The following is a description of a gene set: The reorganization or renovation of existing tissues. This process can either change the characteristics of a tissue such as in blood vessel remodeling, or result in the dynamic equilibrium of a tissue such as in bone remodeling. species: Mus musculus Mouse Gene Set: GOBP_TISSUE_REMODELING, and this is the list of marker genes: Pparg, Hoxa3, Pbrm1, Mmp2, Umod, Itgav, Slc4a2, Jag1, Plg, Cyp1a1, Ltbp3, Abr, Mir29a, Foxc1, Mdm2, Cav1, Rab3d, Dcstamp, Ncdn, Sfrp1, Il6, Elf3, Crb1, Dll4, Tmbim1, Traf6, Cd24a, Mmp9, Atp7a, Nox4, Hamp, Efna2, Hif1a, Il7, Epha2, Tnfrsf11a, Nol3, Cela1, Tgm2, Tgfbr3, Chaer1, Src, Inpp4b (inositol polyphosphate-4-phosphatase, type II), Rac2, Lrp1, Ihh (NCBI Gene Id 16147), Rbpj (NCBI Gene Id 791349), Tcirg1 (T cell, immune regulator 1, ATPase, H+ transporting, lysosomal V0 protein A3), Rock1, Gpr55, Pth1r, Hnf1a, Tpp1, Ahr, Thbs4, Grem1, Stat5a, Atg5, Col6a1, Csf1r, Spp1, Tns3, Lepr, Ptn, Ceacam1, Plekhm1, Rock2, Ankrd11, Cthrc1, BC004004, Fshr, Fcgr4, Ppargc1b, Calcr, Vegfa, Tfrc, Gpr137b, Capn1, Lipa, Ugt1a1, Siglec15, F2r, P2rx7, Ctsk, Gsk3b, Mdk, Timp1, Inpp5d, Ctnnb1, Htr1b, Acvr2b, Bcr, Sema3c, Gnat2, Npr3, Tbx1, Wnt16, Pml, Cartpt, Ddr2, Cd38, Dock5, Ndp, Npr2, Chd7 (NCBI Gene Id 57137), Itgb3, Notch2, Axl, Klf6, Arap1, Fam114a1, Il18, Ptk2b, Angpt2, Spp2, Fshb, Adrb2, Nppc, Egfr, Syk, Fgf10, Il1a, Rufy4, Gpnmb, Bak1 (NCBI Gene Id 12018), Lrrk1, Snx10, Itga4, Cldn18, Ccdc154, Tnfrsf11b, Herc1, Gja5, Acvrl1, Lrp5, Ppp3ca, Abcb1b, Trf, Adra1b, Mitf, Dbh, Tie1, Fgfr3, Vdr, Prkca, Epas1, Fkrp, Def8, Fgf8, Slc34a1 (solute carrier family 34 (sodium phosphate), member 1), Nos3, Mir29b-1, Cspg4, Iapp, Suco, Oscar (osteoclast associated receptor), Cbl, Tgfb2, Gdf5, Nf1, Syt7, Mmp14, Csk, Lif, Rac1, Lep (leptin), Agt, Il23a, Ednra, Clec10a, Ccr2, Acp5, Rassf2, Hrg, Adam8, Cdkn2a, Flt4, Tph1, Enpp1, Hand2, Tmem64, Rab7 (RAB7, member RAS oncogene family), Fosl2, Mir29c, Flna, Cbs, Mef2c, Lrp6, Nfkb1, Ptger4, Ubash3b, Ccl2, Gpr137, Bsx (NCBI Gene Id 244813), Tmem119, Cst3, Bbln, Rspo3, Il20ra, Ctss, Mir29b-2, Lrrc25, Idua, Gja1, Dlk1, P3h4, Cts8, Ext1, Ahsg, Nos2, Bax, Tnfsf11, Eln (elastin), Bmpr2, Igf1, Pdk4, Lgr4, Car2, Nfatc3, Foxc2, S1pr1, Gata4, Trp53, Mc4r, Cyp19a1 (NCBI Gene Id 13075), Igfbp5, Ypel4, Eva1a